The following is a description of a gene set: studied in species Mus musculus Cytokines mediate cell-cell communication in the immune system and represent important therapeutic targets. A myriad of studies have highlighted their central role in immune function, yet we lack a global view of the cellular responses of each immune cell type to each cytokine. To address this gap, the authors created the Immune Dictionary, a compendium of single-cell transcriptomic profiles of more than 17 immune cell types in response to each of 86 cytokines (>1,400 cytokine-cell type combinations) in mouse lymph nodes in vivo. A cytokine-centric view of the dictionary revealed that most cytokines induce highly cell-type-specific responses. For example, the inflammatory cytokine interleukin-1β induces distinct gene programmes in almost every cell type. A cell-type-centric view of the dictionary identified more than 66 cytokine-driven cellular polarization states across immune cell types, including previously uncharacterized states such as an interleukin-18-induced polyfunctional natural killer cell state. Genes positively differentially expressed in cell type: cDC2 (conventional dendritic cell type 2) upon treatment with cytokine: IFN-γ in mouse lymph nodes in vivo. from publication Cui A, Huang T, Li S, Ma A, Pérez JL, Sander C, Keskin DB, Wu CJ, Fraenkel E, Hacohen N (PMID 38057668) Mouse Gene Set: CUI_CDC2_IFNG_RESPONSE_UP, and this is the list of marker genes: Sik3, Snu13, Hif1a, Pdcd6ip, Dcp2, Atp5me, Tgtp2, Pik3cd, Hipk2, Chd7, Wars1, Nras, Slfn8, Snx6, Serpinb9, Flnb, Rbms1, Vwa5a, Csf2rb2, Cflar, Ptpn2, Trafd1, Ifi206, Xpo6, Psma3, Il1rn, Usp18, Gpr108, Fyn, Il4ra, Slc4a8, Lcp2, Tapbpl, H2-K1, Pcgf5, Znhit1, Gsdmd, Ldha, Sf3b6, Zyx, Mfsd1, Ass1, Gbp3, Gpr132 (G protein-coupled receptor 132), Phc2, Capn1, Mthfd2, Slfn2, Eif1a, Rcn1 (reticulocalbin 1, NCBI Gene Id 19672), C1qb, Manf, Sod2, Uba1, Tnfaip2, Ccnd1, Marcksl1, Ifi207, Caprin1, Vdac2, Scimp, Sh3bp2, Plekhb2, Rbbp8, Kdr, Prelid2 (PRELI domain containing 2), Taf13, Pfn1, Ralgds, Ctsc, Ywhaq, Parp11, Atp6v1d, Jpt1, Ifitm3, Rhbdf2, Ggct, Casp1, Rtp4, Cstb, Gls, Irf7, Coro2a, Arl8b, Pmvk, Rpn1, Fam241a, Irf8, Bbx, Rigi, Trim30d, Chmp4b, Cd86, Glrx, Edem1, Lrrc8c, Ifi213 (interferon activated gene 213), Apobec3 (apolipoprotein B mRNA editing enzyme, catalytic polypeptide 3), Actr2 (actin related protein 2), Ifitm1, Ccnd2, Ranbp1, Actg1, Cd40, Psmb8, Il21r, Pmepa1, Abhd16a, Sub1, Cox7b, Clic4, Ppp2r1a, Lpp, Dcun1d1, Gnptab, Hnrnpa2b1, Mif, Gosr2, Serpina3f (NCBI Gene Id 257657), Oxct1, Rsl24d1, Bcl2a1d, Selenow, Dram1, Ifi211, Cacybp, Psmb4, Rbm3, Mvp, Gpr141 (G protein-coupled receptor 141), Procr, Snrnp27, Snx10, Sem1, Fgl2, Gbp8, Ilrun, Anpep, Cldnd1, Ms4a4c, Slc33a1, Vcam1, Rab11a, Stx7, Slc30a1, Tnf, Gbp7, Trim30a, Ppp1r15b, Gmppb, Acadl, Dbnl, Zup1, Hnrnph2, Max (Max protein), Arf6, Kit, Spi1, Usp25, Myo1e, Pdia6, Ndufs4, Irgm1 (immunity-related GTPase family M member 1), Rnf213, Akap9, Evl, Bbip1, Neurl1b, Ifih1, Arfgef1, Cdkn1a, Tuba1b, Tagln2, Il10ra, B2m, Oas3, Basp1, Irgm2, Myl12a, Stk19, Cndp2, AA467197 (NCBI Gene Id 433470), Eif5a, Psme1, Igtp, Atp5mc3, Slfn1, Rnf114, Clec2d, Gbp2, Ly6a, Uba7, Dock4, Ube2d3, Nlrc5, Ywhag, Ccl12, Gatm, Vim, Plaat3, Serpina3g, Ifi27l2a, Rab7, Ly6i, Ebp, Man2a1, Dnajc3, Bak1, Atp5f1b, Ifi35, H2-Q4, Agfg1, Tspan13, Rab1a, Endod1, Ube2l6, Myd88, Ccl2, Socs3 (NCBI Gene Id 12702), Pgs1, Cyld, Prr13, Oasl2, Larp1, Zc3hav1, Tmem106a, Cxcl10, Hat1, Cyrib, Gbp6, Lyn, Fcgr4, Ddx39a, Rcn2, Prdx1, Dynll1, Cttnbp2nl, Arid5b, Nsmce1, Pml, Cxcl16, Nfkbib, Ptpn6, Znfx1, Tomm70a, Sp140, Bcl2a1b, Ran, Aida, Actr10, Hmgcr, Cfl1, Psmd13, Zbp1, Bcl2a1a, Sell, Dok2, Casp4, Gsap, Tns3, Dnaja2, Idnk, Psmd2, Pdcd10, Zfand3 (zinc finger, AN1-type domain 3), Parp9, Mndal, Gca, Slamf7, Tbkbp1, Slamf8, Alyref, Capza1, Axl, Akr1a1, Tor3a, Gda, Elob, Nrp2, Arf3, Ptpn1, Tapbp, Fas, Eif2ak2, Ndufb7, Tcf7l2, Rmdn3 (regulator of microtubule dynamics 3), Slc2a1, Sdc4, Hck, Morf4l2, Capzb, Flot2, Ly6e, Isg15, Ldlr, Ifi47, Slfn9, Irf9, Tubb4b, Tmbim6, Mxd1, Rab5c, Sdcbp, Entpd1, Guca1a (guanylate cyclase activator 1a (retina)), Ifi203, Mlkl, Tap2, Tmem128, Dtx3l, Ifi209, Eepd1, Stat3, Bcl2l14, Phf11a, H2-T22, Hk3, Sp100, Socs1, Sbno2, Cmpk1, Cnn3, Lgals9, Il2rg, Cox7a2, Gapdh (glyceraldehyde-3-phosphate dehydrogenase), Cfb, Klrk1, Bst2, Slc31a1, Parp12, Psma4, Ttc39b, Cd274, Clcn7, M6pr, Etnk1, Rala, Txn1, Arf4, Irf1 (interferon regulatory factor 1), Dnase1l3, Icam1, Phf11b, Pkib, Ifit2, G3bp2, Stat1, Sec61g, Rnase6, Tgtp1, Arf5, Ost4, Fus, H2-T23, Ppa1, Pnp, Csf2ra, Sting1, Rnf19b, Gbp9, Calm1, Prpf31, Thoc6, Usp12, Ddx6, Rnaseh2b, Peli1, Cmtm3, Ube2d2a, Eml4, Ier3ip1, Scfd1, Slc8b1, Calhm6, Tmsb10, Efhd2, Anxa4, Slco3a1, Ppt1, Cycs, App, Nod1, Wdr1, Rassf2, Psmb9, Nmi, Grn, Nup153, Coa5, Tor1aip1, C3, Lamp2, Slc15a3 (NCBI Gene Id 65221), Gnb4, Lap3, Parp14, Psma7, Pcmtd1, Samhd1, Tagap, Slfn5, Adap1, Marchf5, Daxx, Eif1ax, Nrp1, Psme2, Tmem131, Phf11d, Hnrnpd, Pkm, Aig1, Hspa8, Fbxl5, Trim12c, Gramd2b, Il15ra, Il18bp, Psme3, Pdia3, Calr, Tspo, Psmb10, Clip2, Tgm2, Sumo2, Ccz1, Vwf (Von Willebrand factor), Srsf3, Hnrnpa3, Batf2, Psma5, Mov10, Gnb1, Tle3, Plac8, Hspa5, Smchd1, Ogfr, Gbp4, Zfp800, Sdc3, Stx3, Magohb, Dnajc21, Trim26, Xaf1, Tuba1a, Nampt, Pfkp (phosphofructokinase, platelet), Sp110, Cd300lf, Ece1, Psma2, Capza2, Ywhae, Ncf1 (NCBI Gene Id 17969), Cers6, Denr, Sppl2a, Gabarap, Epsti1, Stat2, Fcgr1, Fcgr3, Mpeg1, Mapkapk2, Iigp1 (interferon inducible GTPase 1), Noc4l, Bst1, Tpm4, Mdm2, Tap1, Prkx, Vamp8, Pomp, Rars1, Actr3 (NCBI Gene Id 74117), Crybg1, Arl2, Bcl3, Herc6, Mapk1ip1l, Pla2g4a (NCBI Gene Id 226493), Nudt19, Tmbim4, Shisa5, Ly86 (NCBI Gene Id 17084), Creb3, Alkbh1, Tpm3, N4bp1, Atp1b3, Stx2 (syntaxin 2), Oas1a, Gbp5, Srsf2, Atp8a1, Ciita, Naaa, H2-D1, Ifi205, Adam15, Eif4a1, Rpf2, Tgfb1, Ifi204, Cd69, Cxcl9, Hprt1, Themis2